The following is a description of a gene set: This event has been computationally inferred from an event that has been demonstrated in another species.<p>The inference is based on the homology mapping from PANTHER. Briefly, reactions for which all involved PhysicalEntities (in input, output and catalyst) have a mapped orthologue/paralogue (for complexes at least 75% of components must have a mapping) are inferred to the other species. electronically inferred by orthology from the curated human pathway species: Mus musculus part of: Nucleotide-binding domain, leucine rich repeat containing receptor (NLR) signaling pathways Reactome Pathway: Inflammasomes, and this is the list of marker genes: Bcl2l1, Aim2, P2rx7, Mefv, Nlrp3, Sugt1, Pstpip1, Txn1, Panx1, Pycard